Given this list of marker genes Nlrp4c, Rnf26rt, Fpr2, Pcbp2, Samhd1, Ddx39a, H2-M3, Npy, Eif4e2, H2-T23, Clec12b, Mdk, Cd96, Fgl2, Serpinb9, Nfkb1, Ifnb1 (interferon beta 1, fibroblast), Nlrc5, Ilrun, Smad3, Ptger4, Usp18, Il22, Irgm1, Ins2, Nr1h3, Nlrp4e, Oas1h, Tgfb1, Tnfaip8l2, Pten, Foxf1, Slamf8, Nlrp12, Il2, Il10ra, Extl3, Npy5r, Ifi206, Otop1, Oas1b, Lyar, Klrb1b, Krt1, Drd2, A2m (NCBI Gene Id 232345), Adipoq, Aoah, C1qtnf3, Banf1, Socs3, Mavs, Ceacam1, Alox5, Tap1, Psmb4, Enpp3, Siglece, Ppm1b, Ins1, Hgf, Mmp12, Clec2d, Muc19, Cx3cr1, Sh2d1b2, Ndfip1, Mapkbp1, Oas1d, Pdcd10, Socs5 (NCBI Gene Id 69052), Fndc4, Bcr, Ifi209, Zdhhc18, Nt5c2, Fpr-rs6, Tmsb4x, Ghsr, Il12b, Lrfn5, Hamp, Sbno1, Nlrp4f, Nlrx1, Rora, Serpinb9b, Ldlr, Zfp36, Gpx1, Cd200l1, Mvk, Foxp3, Pim1, Tafa3, Atg5, Usp15, Ifi213, Fam3a, Itch, Klre1, Proc, Mkrn2, Ffar4, Cxcl17, Arrb2, Dusp10, Oas1f (2'-5' oligoadenylate synthetase 1F), Fpr-rs7, Uaca, Apoa1, Isg15, Ctla2a, Nod2, Lpcat3, Tnfaip6, Tnfrsf1b, Smpdl3b, Serping1, Dtx4, Gata3, Nlrp4a, Git1, Grb2, Metrnl, Irak3, Cd24a, Nr5a2, Arnt, Mir7578, Ccn3, Ppara, Dcst1, Ccr1, Gigyf2, Il33, Il20rb, C1qbp, Sirpa, Fem1al, Cep63, Dhx58, Nectin2 (NCBI Gene Id 19294), Arg1, Acp5, Cdh5, Pbk, Ahr (aryl-hydrocarbon receptor), Crk, Pla2g5, Mndal, Cd200, Gfer, Trim38, Inpp5d, Tap2, Traf3ip1, Il2ra, Cx3cl1, Nlrp3, Cnot7, Ppard, Il22b, Pglyrp1, Cactin, Parp1, Syt11, Adora2a, Il13, Mettl3 (NCBI Gene Id 80554), Gps2, Igf1, Tnfrsf1a, Mfhas1, Fpr-rs4, Adora1, Cyld, Tarbp2, Gpr31b, Aurkb, Ptgis, Serpinb9c, Ythdf3, Cck, Spn, Htra1, Ifi208, Pla2g10, Serpinb9d, Gper1, Elf4, Ier3 (NCBI Gene Id 15937), Ywhaz, Fxr1, Sfn, Arg2, Ptpn6, Ppp1r13l, Fpr-rs3, Ifi207, Trem2, Adar, Cd276, Trim21, Ythdf2, Acod1, Nr1d2, Mill1, Mefv, Nmi, Oas1c, Cyp19a1 (cytochrome P450, family 19, subfamily a, polypeptide 1), Mir147, Ada, Lgals9, Cst7, Otulin, Rabgef1, Grn, Nr1d1, Oas1g, Oas1e, Nr1h4 (nuclear receptor subfamily 1, group H, member 4), Ifi214, Apoe, Chrna7, Oas3, Ash1l (ASH1 like histone lysine methyltransferase), Reg3a, Il17a (NCBI Gene Id 16171), Reg3g, Gpr17, Serpinb9f (serine (or cysteine) peptidase inhibitor, clade B, member 9f), Ifi203-ps (NCBI Gene Id 100504287), Nr1h5 (nuclear receptor subfamily 1, group H, member 5), Ptpn2, Stat3, Wfdc1, Cd200r1, Clec12a, Vsig4, Fam76b, Fem1a, Ttll12, Sharpin, Smim30, Vps35, Gpx2, Serpinb9h, Il10, Il22ra1, Trim45, Macir, Mul1, Rnf26 (NCBI Gene Id 319795), Slc39a8, Fcgr2b (Fc receptor, IgG, low affinity IIb), Nlrp6, Abr, Selenos, C1qtnf12, Igf2, Klrd1, Sod1, Pparg, Nlrp4b, Siglecg, Serpinb9g, Tyro3, Cd200l2, Rps19, Oas1a, Stat2 (NCBI Gene Id 80602), Isl1, Trex1, Cd44, Trafd1, Susd4, Ets1, Parp14, Trim65, Tff2, Il4, Rb1, Il22ra2, Nr1h2, Irgm2, Dsg2, Nt5e, Serpinb9e, Igtp (NCBI Gene Id 16145), Dnaja3, Usp38, Havcr2, Nectin4, Atg12, Ifi203, Ghrl, Gstp1, Pf4, Sh2d1b1, Tnfaip3, Nlrc3, Psma1, Adcyap1, here is a description of the gene set: Any process that stops, prevents, or reduces the frequency, rate or extent of a defense response. species: Mus musculus Mouse Gene Set: GOBP_NEGATIVE_REGULATION_OF_DEFENSE_RESPONSE